The following is a description of a gene set: The chemical reactions and pathways resulting in the breakdown of glycerolipids, any lipid with a glycerol backbone. studied in species Homo sapiens Human Gene Set: GOBP_GLYCEROLIPID_CATABOLIC_PROCESS, and this is the list of marker genes: ABHD16A (abhydrolase domain containing 16A, phospholipase), APOA5, PRDX6, PNPLA2, PNLIPRP2, LIPE, SCARB1, LDLR, APOC2, CPS1, PLA2G15 (NCBI Gene Id 23659), ABHD16B, PIK3CG, PLA2G4D, LIPG, ABHD12B, AADAC, PLA2G4F, PNLIPRP1, ABHD5, GDPD3, PLA2G7, ABHD6, PNPLA8, SORL1, APOC3, PLA2G4B, GDPD1, APOC1, PLA2G5 (NCBI Gene Id 5322), APOB (apolipoprotein B), GPLD1, FAAH, PLCB1, PLA2G6, LPL (lipoprotein lipase), APOA4, PLA2G4E, DAGLB, PLA2G4A, LIPC, PNPLA4, ABHD2, PNPLA3, GPCPD1, PNPLA7, FUT1, GDE1, SMPD4, DAGLA, PNPLA1, ENPP6, DDHD2, GPIHBP1, INPP5F, APOA2, DGKD, PNPLA6, PNLIP, PLB1, PLA2G10, PNPLA5, ABHD12, PLIN5, PLA2G4C, PNLIPRP3, LYPLA2, ENPP2, MGLL